The following is a description of a gene set: Mouse Gene Set: GOBP_REGULATION_OF_B_CELL_MEDIATED_IMMUNITY species: Mus musculus Any process that modulates the frequency, rate, or extent of B cell mediated immunity., and this is the list of marker genes: Rif1, Cd55, Cd226, 6030468B19Rik, Hpx, H2-T23, Il27ra, Shld3, Fcgr1 (Fc receptor, IgG, high affinity I), Nod2, Atad5, Aplf, Nsd2, Cr2, C3, Shld2, Il2, Mir181b-2, Hmces, Xcl1 (chemokine (C motif) ligand 1), Trem2, Gimap5, Tgfb1, Tnf, Ndfip1, Tnfsf4, Ighg1, Shld1, Foxj1, Ptpn6, Fcgr3, Fcer1a, BC037156, Bcl6, Pms2, Supt6 (NCBI Gene Id 75730), C4bp, Tbx21, Lta, Fcgr2b, Fcer1g, Fcer2a, Stat6, Kmt5c, Parp3, Foxp3, Kmt5b, Cr1l, Tnfsf13, Clcf1, Zp3r, Ighg2b, Susd4, Il4, Exosc6, Ifng, Pagr1a, Paxip1, Mir181b-1, Mad2l2, Cd28, Slc15a4, Exosc3, Gimap3, Msh2, Cd46, Trp53bp1 (NCBI Gene Id 27223), Mlh1, Btk, Cd40, Tfrc, Nectin2, Ptprc